The following is a description of a gene set: We used microarrays to detail the global programme of gene expression by circulating TCRVgamma9+ gamma delta T cells isolated from healthy individuals,tested either as resting cells or cells activated by phosphoantigen BrHPP and IL-2at an early(+6hrs) and a late (+7days) timepoint. We find that with more “NK cell” genes than alphabeta T cells and more “T cell” genes than NK cells, the circulating TCRVgamma9+ gamma delta T cells cells have a hybrid transcriptome. The gene signature of the activated cells recapitulates their physiological functions: Th1 cytokine, chemokine and cytotoxic activities at first and mitotic activity at later time points. The gene expression pattern of activated normal gamma delta T cells is nevertheless clearly distinctive from that of NK/T and peripheral T cell lymphomas of the gamma delta subtype. Genes down-regulated in gamma delta T cells activated by phophoantigen BrHPP and IL2: 0h versus 7 days. species: Homo sapiens from publication Pont F, Familiades J, Déjean S, Fruchon S, Cendron D, Poupot M, Poupot R, L'faqihi-Olive F, Prade N, Ycart B, Fournié JJ (PMID 21968650) Human Gene Set: GSE27291_0H_VS_7D_STIM_GAMMADELTA_TCELL_DN, and this is the list of marker genes: RANBP9, HAPSTR1, TARDBP, ENSG00000272447, ZNF837, CSNK1D, ABCG1, SGSM2, HSPA1A, EVL, MAX (NCBI Gene Id 4149), DGKA, HCST, ZNF304, PIP4K2A, CLK1, TNFRSF12A, ARHGAP9, MIR4453HG, LOXL1-AS1, ATF3, MAML1, DOK2, MXRA7, EFNA4, PHF13, SLC25A30, IGSF8, CD96, PLEKHO1, TXNIP, AXDND1, CPO, SF3A2, ATP11C, ZBTB17, SSX2IP, UTRN, MEGF9, DUSP5, CPD, PHC2, CDKN1A, LYST (lysosomal trafficking regulator), SFMBT1, KMT2C, STXBP5, JUND, ANKRD11, LFNG, CDK17, CHADL, FOXJ2, MEAF6 (NCBI Gene Id 64769), BPTF, MLKL, ZNF134, ENSG00000254531, DQX1, FAM169A, WDR44, DUSP2, ZBTB33, IFT122, MELK, CREBBP (CREB binding protein), MRPL2, PITRM1, FAS, ZBTB11, BHLHE40, ABHD5, TBC1D10C, SP4, PIK3CA, RAB30-DT, OSBPL8, SMAD3, KHDC4, ZNF776, CASTOR3P, DENND4C, SKI, KLRA1P, RNMT, RAP1B, CR2, SPMIP10, GADD45B, RPRML, CXXC5, ZNF644, TMEM131L, HAL, ADAM10, PHTF2, RNF38, USP20, ABHD3, BTG1, SEMA4D, RASSF5, RHOQ (ras homolog family member Q, NCBI Gene Id 56679), ZNF567, FUT8-AS1, SHFL, KDM2B, SLC22A4, CLK4, SLC26A6, ZNF606, PARVG, CDKN3, N4BP2L1, CCNI, ITSN2, MMD, SYPL1, CDKN2D, PPM1D, RBMX, ANKUB1, LTB, TOP2B, SEPTIN11, PLEKHF2, RHOH, P4HA2, PTPN7, ITPRID2, ERCC6L2-AS1, ASPA, ENSG00000293232, H2AC15, WDR26, GAB3 (NCBI Gene Id 139716), MAPK13, PHIP, HELZ, SMCHD1, NAB2, GFI1, BTG2, SLC25A25, UPP1, ZFAND6, DENND1B, ARMC8, COQ8A, ZNRF2, LCK, USP9Y, ZNF597, C16orf54, ESYT1, CLIP4, TRAC, NOL4L, TAPBPL, NCR3, DUSP22, TMC8, PPIL4, ZBTB16, HORMAD1, CSRP2, TENT5C, SIT1, FAM111A, ITGAL, GHDC, TLE4 (TLE family member 4, transcriptional corepressor), ZMYM2, JADE1, ALCAM, KIF23, SLC12A6, GLRX, NTNG2, SCN9A (sodium voltage-gated channel alpha subunit 9), TFRC, CYP2R1, ARNT, MEX3C, DOCK8, NF1, FAM161A, ITPR3, RPS6KA5, LNX2